The following is a description of a gene set: Pilocytic astrocytomas (PAs) are the most common glioma in children. Whereas many PAs are slow-growing or clinically indolent, others exhibit more aggressive features with tumor recurrence and death. To identify genetic signatures that might predict PA clinical behavior, we did gene expression profiling on 41 primary PAs arising sporadically and in patients with neurofibromatosis type 1 (NF1). Whereas no expression signature was found that could discriminate clinically aggressive or recurrent tumors from more indolent cases, PAs arising in patients with NF1 did exhibit a unique gene expression pattern. In addition, we identified a gene expression signature that stratified PAs by location (supratentorial versus infratentorial). Lastly, we also identified a gene expression pattern common to PAs and normal mouse astrocytes and neural stem cells from these distinct brain regions as well as a gene expression pattern shared between PAs and another human glial tumor (ependymoma) arising supratentorially compared with those originating in the posterior fossa. These results suggest that glial tumors share an intrinsic, lineage-specific molecular signature that reflects the brain region in which their nonmalignant predecessors originated. from publication Sharma MK, Mansur DB, Reifenberger G, Perry A, Leonard JR, Aldape KD, Albin MG, Emnett RJ, Loeser S, Watson MA, Nagarajan R, Gutmann DH (PMID 17283119) Human Gene Set: SHARMA_ASTROCYTOMA_WITH_NF1_SYNDROM Genes up-regulated in pilocytic astrocytoma (PA) samples from patients with type 1 neurofibromatosis syndrom (NF1) compared to the PA tumors from non-NF1 patients. species: Homo sapiens, and this is the list of marker genes: MAP3K7CL, CLEC3B, ADGRV1, STN1, SLC1A3